The following is a description of a gene set: studied in species Mus musculus Mouse Gene Set: GOBP_REGULATION_OF_RESPIRATORY_SYSTEM_PROCESS Any process that modulates the frequency, rate or extent of a respiratory system process, an organ system process carried out by any of the organs or tissues of the respiratory system., and this is the list of marker genes: Fto, Gls, Nlgn2, Pbx3, Glra1, Nlgn3, Cc2d1a, Phox2b, Nlgn1, Mecp2, Tshz3, Gsx2, Mtg1, Atp1a2, Tlx3, Mtg2, Adora1